The following is a description of a gene set: Bacillus anthracis bacteria target cells in an infected human through the action of three secreted bacterial proteins, lef (also known as LF, lethal factor), cya (also known as EF, edema factor), and pagA (also known as PA, protective antigen). lef is a protease that cleaves and inactivates many MAP2K (MAP kinase kinase, MEK) proteins, disrupting MAP kinase signaling pathways. cya is an adenylate cyclase that mediates the constitutive production of cAMP, a molecule normally generated transiently in tightly regulated amounts in response to extracellular signals. Both lef and cya depend on pagA to enter their target cells, a strategy characteristic of bacterial binary toxins. pagA binds to the target cell receptors, is cleaved by furin or other cellular proteases, and thereupon forms an oligomer that exposes binding sites for lef and cya molecules. This complex is taken into the target cell by clathrin mediated endocytosis and delivered to endosomes. The low pH of the endosome causes the bacterial toxin complex to rearrange: the pagA oligomer forms a pore in the endosome membrane through which lef and cya molecules enter the target cell cytosol. part of: Uptake and actions of bacterial toxins studied in species Homo sapiens Reactome Pathway: Uptake and function of anthrax toxins, and this is the list of marker genes: MAP2K7, CALM1, pagA, MAP2K6, MAP2K3, MAP2K4, PDCD6IP, ANTXR2, ANTXR1, FURIN, lef, MAP2K2, cya, MAP2K1